The following is a description of a gene set: During acute viral infections, naïve CD8+ T cells differentiate into effector CD8+ T cells and, after viral control, into memory CD8+ T cells. Memory CD8+ T cells are highly functional, proliferate rapidly upon reinfection and persist long-term without antigen. In contrast, during chronic infections, CD8+ T cells become “exhausted” and have poor effector function, express multiple inhibitory receptors, possess low proliferative capacity, and cannot persist without antigen. To compare the development of functional memory T cells with poorly functional exhausted T cells, we generated longitudinal transcriptional profiles for each. studied in species Homo sapiens from publication Doering TA, Crawford A, Angelosanto JM, Paley MA, Ziegler CG, Wherry EJ (PMID 23159438) Genes up-regulated in CD8 T cells: naïve versus effectors at day 15 chronic infection with LCMV-clone 13. Human Gene Set: GSE41867_NAIVE_VS_DAY15_LCMV_CONE13_EFFECTOR_CD8_TCELL_UP, and this is the list of marker genes: NELL2, GEMIN4, LINC00174, VWA8-AS1, ACRV1, SPDYE1, SPATA6, MYT1L, DUXAP10, FMR1NB, CFAP54, MYL11, ENSG00000240207, DSCC1, TNNC2, PNLIPRP1, ADGRG4, PHF21B, CHEK2, ZNF157, CFAP99, TCERG1, FOS, LINC00951, CHRD, AICDA, PLPP3, AMER2, PIRT, IGHD, OSM, RRN3P2, AGO3, ALB, HOXA9, CLEC1B, MYO1D, PTPRF, TSEN34, ELAVL4, KLK5, TPTE2P6, CBX2, LINC01126, UCA1, GOT1L1, SPATA12, NRXN3, HGF, ASPDH, TNF, DLG5, TTLL2, ART5, MIR4290HG (NCBI Gene Id 286370), LRP5, C1orf127, NT5E (5'-nucleotidase ecto), PLA2G2A, WDR97, ENSG00000293232, ETV2, FOXI1, MUS81, MAB21L3, B3GNT8, RECK, ENSG00000280119, SYNE3, CYS1, LINC00029, SOCS4, SNAPC2, IMPG1, RNF180, GPR84, GPR37, KCNH1, AFF3, SELE, ABCC2, CPLX2, ZNF100, PCAT19, DLGAP2, ITIH3, DNAAF8, C15orf32, CCDC116, GTF3C2-AS1, EDDM3A, TEX38, RDM1, NFIX, TNS2 (NCBI Gene Id 23371), GJB5, KIT, SLC38A3, PTCHD4, KRT83, PDZRN3, LINC02582 (NCBI Gene Id 100509395), C7, CDH24, PGK2, PLCD4, TPPP, VEPH1, EFCAB3, PITX2, AZGP1P1 (NCBI Gene Id 646282), ZNF853, SCGB2A1, TTC38, FAM86C1P, PHYHD1, C6orf15, NR4A2, MIA2, ZAN, ZFR2, PRAC2, CCDC7, RNF213-AS1, USP43, GRID2, HSD3B1, TFCP2L1, KLF3-AS1, LINC00626, GPRIN1, HHIPL2, RSPH9, G2E3, PARD6G, KCNA2, TAS1R2, GPR183, ICOSLG, GPR35, TSPO2, PYCR3, EMCN, IRF6, A4GALT, OSGIN1, LCK, RDH12, NCAN, LUZP2, RHD, CDC14C, FOXN4, CARD18, CFAP95-DT, SCUBE2, MACROD1, DGCR8, ADAMTSL3, CPNE5, CXorf51A, LRRC32, HTR5A, PCARE, MYO5B, MLPH, WDR55 (WD repeat domain 55), HACE1, SCAMP5, CAPN6, LRRC77P, PGA3, NUDCD1, HCN1, SEPTIN7P2, CLCNKB, HPCA (hippocalcin), DDX1, CLIP3, LINC02510, KRT2 (NCBI Gene Id 3849), CDC25C, NLRP12, PYGO1, PPP3R2, CLDN6, MYBPH (NCBI Gene Id 4608)